Given this list of marker genes FCER1G (NCBI Gene Id 2207), TLR3, FCER1A (NCBI Gene Id 2205), CD1D, CD1B, DCP1B, DCSTAMP, TIRAP, CCL16, FCGR3A, CCL20, NOD2, FAS, TLR9, LILRB4, NOD1, CD80, CD1A, HLA-DRB1, TAP1, CCR1, ADAMDEC1, HLA-DQB1, TLR8, CD86, CCR3, TLR10, CD74, FCGR2B, CD81, HLA-DMA (NCBI Gene Id 3108), ICAM2, TRAF6, CD209, TICAM1, TLR2, B2M, DCTN2, CD1C (NCBI Gene Id 911), CCL17, SOD2, CCL21, TLR6, CCR2, CD44, CCL22, HLA-DMB, CD68, TLR5, CARD8, TLR7, IRAK2, TLR1, CD58, FCGR2A, ICAM1, MYD88, TLR4, CCR5, CDC42, here is a description of the gene set: The live vaccine strain (LVS) of Francisella tularensis is the only vaccine against tularemia available for humans, yet its mechanism of protection remains unclear. We probed human immunological responses to LVS vaccination with transcriptome analysis using PBMC samples from volunteers at time points pre- and post-vaccination. Gene modulation was highly uniform across all time points, implying commonality of vaccine responses. Principal components analysis revealed three highly distinct principal groupings: pre-vaccination (-144 h), early (+18 and +48 h), and late post-vaccination (+192 and +336 h). The most significant changes in gene expression occurred at early post-vaccination time points (<=48h), specifically in the induction of pro-inflammatory and innate immunity-related genes. Evidence supporting modulation of innate effector function, specifically antigen processing and presentation by dendritic cells, was especially apparent. Our data indicate that the LVS strain of F. tularensis invokes a strong early response upon vaccination. This pattern of gene regulation may provide insightful information regarding both vaccine efficacy and immunopathogenesis that may provide insight into infection with virulent strains of F. tularensis. Additionally, we obtained valuable information that should prove useful in evaluation of vaccine lots as well as efficacy testing of new anti-F. tularensis vaccines. studied in species Homo sapiens from publication Fuller CL, Brittingham KC, Porter MW, Hepburn MJ, Petitt PL, Pittman PR, Bavari S (PMID 17349694) Human Gene Set: FULLER_PBMC_F_TULARENSIS_VACCINE_LVS_AGE_22_54YO_48HR_UP Genes up-regulated in peripheral blood mononuclear cell 48h vs 0h in adults (22-54) after exposure to F. tularensis vaccine LVS, time point 48H